Given this list of marker genes Usf2, Mlx, Ogt, Mlxipl, Sik2, Srf, Usf1, Kat2b, here is a description of the gene set: Any process involving glucose that activates or increases the rate of transcription. Mouse Gene Set: GOBP_POSITIVE_REGULATION_OF_TRANSCRIPTION_BY_GLUCOSE species: Mus musculus